The following is a description of a gene set: Any process that activates or increases the rate of an ATP-dependent activity. studied in species Homo sapiens Human Gene Set: GOBP_POSITIVE_REGULATION_OF_ATP_DEPENDENT_ACTIVITY, and this is the list of marker genes: PLSCR1, DNAJB2, PFN1, PFN2 (NCBI Gene Id 85837), RGN, MYL4, TOR1AIP2, DNAJC9, HNRNPU, AHSA1, ATP2A1, CHTOP, FGF10, DNAJC24, TNNT3, VMP1, TNNT2, TOR1AIP1, SETMAR, GABARAPL2, SSBP1, MYL3, DNAJB11